The following is a description of a gene set: Human Gene Set: GSE13411_NAIVE_VS_SWITCHED_MEMORY_BCELL_DN Genes down-regulated in comparison of naive B cells versus Ig isotype switched memory B cells. from publication Good KL, Avery DT, Tangye SG (PMID 19124732) species: Homo sapiens Enhanced secondary Ab responses are a vital component of adaptive immunity, yet little is understood about the intrinsic and extrinsic regulators of naive and memory B cells that results in differences in their responses to Ag. Microarray analysis, together with surface and intracellular phenotyping, revealed that memory B cells have increased expression of members of the TNF receptor, SLAM, B7 and Bcl2 families, as well as the TLR-related molecule CD180 (RP105). Accordingly, memory B cells exhibited enhanced survival, proliferation and Ig secretion, as well as entered division more rapidly than naïve B cells in response to both T-dependent and T-independent stimuli. Furthermore, both IgM and isotype switched memory B cells, but not naïve B cells, co-stimulated CD4+ T cells in vitro through a mechanism dependent on their constitutive expression of CD80 and CD86. This study demonstrates that upregulation of genes involved in activation, co-stimulation and survival provides memory B cells with a unique ability to produce enhanced immune responses and contributes to the maintenance of the memory B cell pool., and this is the list of marker genes: IFITM3, IL7, LGALS1, ENOSF1, DNAH17, MRPL12, B4GALT7, KDM6A (lysine demethylase 6A), SYNGR3, CHD9, TMEM248, NR3C1, ZNF91, FAM136A, RTN3, DELE1, ZMAT3, ARPP19, PTPN22, PIP4K2A, RBMS1, IFITM2, HEXB, EPRS1, PURA, MLST8, DOK3, CCDC85B, VCL, ITGB1, ATP6V0C, TERF2, PHKB, NDUFA9, LCN1, H2BC4, PABPC4, TUBD1, PSMF1, NRXN3, DOCK2, GSTM2, IARS1, PPP6C, RNASE2, TMEM127, MAN2A1, RFPL1, UQCRC1, CAPZA1, GOLGA8A, ARMCX2, NCR3, EIF2D, LHFPL2, IL10RB, MYO7B, EIF2AK1, CKAP2, ATF6B, VAPB, ZNF493, FOLR3, ALDH2, C3AR1, NUDT4, EFR3A, IKBKB, FAS, USP13, TMEM106C, CCDC88A, NIT2, ATF4, VNN1, IRAK1, GOLGA8B, ZGPAT, ADAM20 (ADAM metallopeptidase domain 20), ECHDC3 (enoyl-CoA hydratase domain containing 3), EIF3G, REL, G0S2, PACS2, SCN5A, APOA1, MDH2, ZNF711, P2RX3, RBCK1, MTFR1, MEA1, PGK1, TPD52L2, ABCC1, CD99, TBC1D9, STOM, DYNC1H1, PPM1G, DENND4C, CHP1, ZDHHC7, NARF, CSF3R, PLPBP, SGPL1, RPS6, HS3ST1, MDC1, F8, PRKRIP1, BCKDHA (NCBI Gene Id 593), SCAF4, EIF4B, PPRC1, MTHFD1, TARS2, RBM10, CCDC92, ETNPPL, OSBPL3, NDUFB1, TUFM, ATP5F1B, HMG20A, ZDHHC24, RNF144A, HLA-A, EPN2, POFUT2, CSF2RB, CLPB, TIMM44, PRKCB, NT5E (NCBI Gene Id 4907), P4HB, CCL5, TBL1XR1, P4HTM, IGFBP3, RABGGTA, SLC25A6, LIN7A, RAP2B, METRN, RPL39L, GID8, WIPF2, PMPCA, ETHE1, DDX52, DAAM1, SLC31A2, NCOA6, MAPKAP1, VIM, PPFIBP2, RPL13, PLEKHJ1, ZMYND8, PRSS21, HAGH, STK10, KANK1, DEPDC5, NEDD4L, SLC35C1, AFM, PABPC1, WBP11, VPS35, OGFOD1, ZNF268 (NCBI Gene Id 10795), LOX, POU2AF1, MSI1, GALNT10, KANSL3, LGMN, SUGP2, SPIDR, VKORC1, EDC3, CCRL2, SYK, ADAP2 (ArfGAP with dual PH domains 2), ANXA2P2, USP9X, PTAFR, RAD17, RANBP6, MBTPS1, CERS2, VOPP1, EPM2AIP1, MARCKS, BTN3A2